Given this list of marker genes ATF4, CREBBP, MAFK, EP300, NFE2L2, here is a description of the gene set: NFE2L2 regulating ER-stress associated genes Human Gene Set: REACTOME_NFE2L2_REGULATING_ER_STRESS_ASSOCIATED_GENES studied in species Homo sapiens